The following is a description of a gene set: species: Mus musculus Mouse Gene Set: GOBP_EPITHELIAL_CELL_DIFFERENTIATION_INVOLVED_IN_PROSTATE_GLAND_DEVELOPMENT The process in which a relatively unspecialized cell acquires specialized features of an epithelial cell of the prostate gland., and this is the list of marker genes: Plaur, Esr2, Trp63, Psapl1, Psap (NCBI Gene Id 19156), Ar, Stat5a, Fem1b, Ctnnb1, Hoxb13, Rxra, Wdr77, Foxa1, Notch1, Fgfr2